The following is a description of a gene set: studied in species Homo sapiens Periorbital fullness Increase in periorbital soft tissue. Human Gene Set: HP_PERIORBITAL_FULLNESS, and this is the list of marker genes: GATAD2B (NCBI Gene Id 57459), TWIST2, NSD2, H4C11, TASP1, WDR4, KMT2B, TUBB, FTSJ1, SETD2, KMT2E, MED13, ANKRD17, CHD1, ELN, RPS23, PPP2CA, ATP6V1E1, MAB21L2, CLPB, HS2ST1, HRAS, FGFR2, VPS33A, PCGF2, YY1, NRCAM, TRIO, MLXIPL, ASXL3 (NCBI Gene Id 80816), ARX (NCBI Gene Id 619216), EDEM3, H4C3, H4C5, PLPBP, DOCK7, ZFX, SPEN, MAP3K7, FBXO11, RBMX, RBL2, SRCAP, NRAS, GNE, PEX19